Given this list of marker genes GLDN, NSUN5, ZMAT5, PLCH1, KRT12, BNC2, TMPRSS11A, PPP1R7, NUP98, RAB27A, USP9X, EPOR, PROP1, SLC4A4, CLEC1A, C1orf115, MMP24, TCF21, RNF103, RMND5A, PPM1L, KIAA0040, CRY1, MBD4, KLHL14, NT5E, MOSPD1, SYNM, ZFPM2, RHOQ, KPNA5, REPS1, ITGB1, SLC5A1, SLC25A5, ZNF28, COPS6, KRAS, RIMS2, ERCC6, MBNL1, LVRN, PDCD7, TCHP, TMEM248 (NCBI Gene Id 55069), CLDN16 (NCBI Gene Id 107986170), CEP41, TBC1D7, PLD1, GRIK2, XCL1, ZNF561, SDC3, PKD2, CCDC77, CEP85L, SLC30A4, MS4A2, ANKRD50, ITGA9, TESMIN, CPSF6, CLCC1, SLC25A34, CDNF, MMRN1, ACSBG1, ZNF711, TOMM7, GYPE, PRLR, OSMR, RELT, GABBR1, PIK3C2A, here is a description of the gene set: Genes predicted to be targets of miRBase v22 microRNA hsa-miR-3118 in miRDB v6.0 with MirTarget v4 prediction scores > 80 (high confidence targets). Human Gene Set: MIR3118 from publication Chen Y, Wang X (PMID 31504780) species: Homo sapiens